The following is a description of a gene set: Mouse Gene Set: GOBP_EPIGENETIC_REGULATION_OF_GENE_EXPRESSION species: Mus musculus A process that modulates the frequency, rate or extent of gene expression through chromatin remodeling either by modifying higher order chromatin fiber structure, nucleosomal histones, or cytosine methylation of DNA. Once established, this regulation may be maintained over many cell divisions. It can also be heritable in the absence of the instigating signal., and this is the list of marker genes: Dppa2, Zfp335, Ifi213, H1f0, Ehmt1, Tsix, Mbd3l2, H2ap (NCBI Gene Id 67334), Zdbf2, Apobec1, Prmt5, Chek1, Myocd, Dyrk1a, Cdkn1c, Hdac3, Spin1, Rlim (ring finger protein, LIM domain interacting), Prmt7, Mbd3, Jarid2, Gsk3a, Asz1, Sirt2, Zmpste24 (zinc metallopeptidase, STE24), H2al3, H3f3a, Tex19.2, H19, Dnmt1, Trim28, Kmt2a, Rnf2, Nrde2, Suz12, Zfp869, Ctcf, Ifi208, Atf7ip, Smyd5, Smarca2, Sin3a, Ddx4, Lmnb2, Bmyc, Uty, Ftx, 4930402K13Rik, Tdrd12, Kpna7, Tnp1, H2al1o, H2al1n, Baz1a, Fam47e, Phb1, Rif1, Pole3, Ing2, H2ac19, Lmna, Ubr2, Tet1, H2ac12, Cbx8, Sirt1, Piwil4, 4930480E11Rik, Mcrip1, Ifi207 (NCBI Gene Id 98407), H2ab3, H2ac6, Xist, H2al1b, Ezh1 (enhancer of zeste 1 polycomb repressive complex 2 subunit), Kat8, Mphosph8, Sphk2, Scmh1 (NCBI Gene Id 29871), Mbd3l1, Hdac10, H2ax, Tdg, Hdac9, Zfy2, H2ac4, Ep300, Cenpv, Uhrf2, Setdb1, Suv39h1, Hdac7, Rnf168, Hdac1, Cbx5, H2al1e, Mbd2, Arid4a, Mov10l1, Apobec3, Trip12, Mael, Meg3, L3mbtl1, App, Dppa3, H2al1m, Ifi203, Rbm15b, Setd1a, Zfp42, Sgf29, Eif1, Gnasas1, Hdac2, Bcl6, Mir136, Smarcb1, H2al1k, H2aj, Ddb1, Ezh2, Hmga2, Btbd18, Myc, Egr1, Ifi206, Lrif1, Phf1, H2al2b, Gsk3b, Mta1, Kdm1a, N6amt1, Smarca5, Rsl1, Morc1, H2ac22, Rnf8 (ring finger protein 8), Mir744, Pcgf3, Bahd1, Cbx1, Kcnq1ot1, Tdrd9, Apex1, a, Ash2l, Atad2, Glyr1, H2ac13, H2al2a, Ifi209, Lcor, Dcaf13 (DDB1 and CUL4 associated factor 13), Tet3, Apobec2, H2ac25, Spocd1, H2ac11, Ehmt2, Spi1, Tdrd5, Msl2, Exosc10, Bend3, H2al1f, Hdac8 (NCBI Gene Id 70315), Usp21, Alkbh4, Dubr, Mettl3, Spen, Wdhd1, Usp7, Tut7, Glmn, Vps72, Chaer1, H2ac1, Atf2, Kdm5a, Lmnb1, H2ac21, Uhrf1, Ppm1d, Mis18a, Gm38999, Suv39h2, H1f9, Nr3c1, Phf2, Airn, Piwil1, Resf1, Spty2d1, Stpg4, Smarca1, Phf8, Trp53, Mettl4, Rbbp5, Upf3b, Dnmt3b (DNA methyltransferase 3B), Bap1, Ctcfl, Znfx1, Samd1, Znhit1, Dnmt3a, Smchd1, Hat1, Letmd1, H2ab1, Ythdc1, Rb1, Pcid2, Kmt2d, Mettl23, Piwil2, Tex15, Morc2b, Fkbp6, Pik3ca, Arid4b, Mbd1, Rlf, Mta2, Lhx2, H2ac24, Cggbp1, H2al1j, L3mbtl3, Aicda, Fam47c, Ctr9, Pcgf5, Pabpc1l (NCBI Gene Id 75658), Smarcd1 (SWI/SNF related, matrix associated, actin dependent regulator of chromatin, subfamily d, member 1), Pphln1, Smarcad1, H2az2, Tdrd1, Hnrnpk, Arb2a (ARB2 cotranscriptional regulator A), H3f3b, Mir127, Tasor, Prdm14, Sirt6 (NCBI Gene Id 72769), Wt1, Hnrnpu, H2ac23, Dot1l, Upf3a (NCBI Gene Id 75230), Ifi203-ps, Sirt7, Hotair, Brca1, Wbp2, Tex19.1, Kdm1b, Kdm2a, H1f8, Ndn, Ncor2, H2az1, Lbr, Wdr5, Ifi214, Brd7, Ezhip, Jpx, Tpr, Klf2, Tut4, Zfp445, Alkbh1, Ogg1, Padi2, Bmi1, Tasor2, Macroh2a1, H2ac20, Trmt112, H2ab2, Axin1, Gnas, Gpx1, Morc2a, Upf1, Cdyl, Tfap2c, Rrp8, Rbm14, Tet2, Zfp57, Cbx3, Atrx, H2ac7, Sdr16c5, Macroh2a2, Epc1, Dnmt3l, Atad2b, Trim37, Eed, Mov10, Mtf2, Rbm15, Kmt2b, Dpy30, H2ac8 (H2A clustered histone 8), Hells, Trim27 (NCBI Gene Id 19720), H2ac15, Baz2a, Mndal, Men1, Hdac5, Hdac6, Smarca4, Cdk2, Mycn, Ubr5, Kat7, Hdac4, Dicer1, H2ac10, Mecp2, Crebzf, Hdac11, Phf19 (PHD finger protein 19), Samd7, Kmt2e